The following is a description of a gene set: from publication Wilensky RL, Shi Y, Mohler ER 3rd, Hamamdzic D, Burgert ME, Li J, Postle A, Fenning RS, Bollinger JG, Hoffman BE, Pelchovitz DJ, Yang J, Mirabile RC, Webb CL, Zhang L, Zhang P, Gelb MH, Walker MC, Zalewski A, Macphee CH (PMID 18806801) species: Homo sapiens Increased lipoprotein-associated phospholipase A(2) (Lp-PLA(2)) activity is associated with increased risk of cardiac events, but it is not known whether Lp-PLA(2) is a causative agent. Here we show that selective inhibition of Lp-PLA(2) with darapladib reduced development of advanced coronary atherosclerosis in diabetic and hypercholesterolemic swine. Darapladib markedly inhibited plasma and lesion Lp-PLA(2) activity and reduced lesion lysophosphatidylcholine content. Analysis of coronary gene expression showed that darapladib exerted a general anti-inflammatory action, substantially reducing the expression of genes associated with macrophage and T lymphocyte functioning. Darapladib treatment resulted in a considerable decrease in plaque area and, notably, a markedly reduced necrotic core area and reduced medial destruction, resulting in fewer lesions with an unstable phenotype. These data show that selective inhibition of Lp-PLA(2) inhibits progression to advanced coronary atherosclerotic lesions and confirms a crucial role of vascular inflammation independent from hypercholesterolemia in the development of lesions implicated in the pathogenesis of myocardial infarction and stroke. Atherosclerotic process genes whose coronary expression changed after darapladib treatment. Human Gene Set: WILENSKY_RESPONSE_TO_DARAPLADIB, and this is the list of marker genes: ARRB2, IL1A, EVI2B, GM2A, PLAUR, DENND2D, HLA-DMA, LAIR1, UCP2, SLC27A4, CTSS, CCR1, CCR2, CD68, CXCR3, CD4, CD48, CCL5, ITGB2, NPL, NCF1, BIN2, PLA2G7, PTAFR, CHI3L1, HMOX1, EVI2A, CYBB